Given this list of marker genes HNRNPK, CPE, AMN, EGR2, SDR9C7, IL17B, FGFR1, ALOX15B, RND2 (Rho family GTPase 2), SAPCD2, CMKLR2, SPATA17, LRSAM1, IFNA1, KCNQ4, LGI1, EDN3, ACACB, IL1RN, CBY3, SEMA4C, LYZL1, SAA2, IL1R2, PLA2G2F, ZBTB21, GALNT6, APOLD1, CD164L2, APOM, MARK1 (NCBI Gene Id 55887), HNF4A, SLC2A1, PTGS1, KDM5B, ADAMTSL2, PADI4, INSL6, CLDN7, CD33, ANKRD31, F7, HELZ2 (helicase with zinc finger 2), GNG13, SLCO2A1, LYPD8, EDARADD, MRGPRE, LOXL4, CPA1, CD70, LAMA1, AOC1, ADAMTSL1, IGSF21, MNX1, SRGN, ADRA2A, TTBK1, ADORA2B, SRXN1, CXCL1, RPH3A, HORMAD2, CKMT1B, UGT2B15, TMEM154, DMRTC2, FAM81B, PAQR5, FOSL1, PLXNB1, CASS4, FAM167B, CDKL1, GLI3, TTK, KCND2, SNAI3, PCDH11X, CALR3, MKI67, ITGB1BP2, ESRRB, TMEM174, CADM2, PABPC4L, LRRIQ3, SOCS3, TUT4, PPP1R1C, PTH, DSC3, HTR4, MGMT, DGAT2, ASPHD2, NLRP5, IL10, NID1, PCDH20, CMTM5, FST, CDKN1A, GDF15, MYOCD, ADAM19, CCDC63, CISH, FLNC, ROR1, CCDC65, CLEC4E, ALPG (NCBI Gene Id 251), PTGS2, TERB2, ARMCX4, FBLN1, NRXN1, PPP1R3B, NCAN, PPP1R1B, ITPKC, HDC, ZFP3, KATNAL2, TSPAN7, DNAJB2, MORC1 (NCBI Gene Id 27136), MXI1, PCSK6, MARCKSL1, NKAIN4, GPCPD1, ADPRHL1, SGMS1, PLEK2, STMN4, RASL10B, CCR1, SPP1, STX1B, ANKRD33, SLC2A3, PAX1, OTC, GRIK2, KCNJ12, CYB5R2, ADAMTSL3, CREB3L3, STIM2, KRT84, KLF5, GOT1L1, CFAP45, HS3ST3B1, RDH11, GRIA2, HTR1F, RILPL2, C5orf52, FHL2, FGB, ROBO3, TTN, SERPINA3, GRIN2A, HSPB8, SYTL4, SLC29A4, COX17, MMP9, MIR1915HG (NCBI Gene Id 414251), BAG2, CD40LG, CSTA, FGD4, SOCS1, CACNG3, SFTPD, PABIR1, MMD, GCGR (glucagon receptor), HS3ST1, LHX5, GNA13, MAP7, FOXM1, MAGI2, PXK, TEX38, MALL, MYOC, ETS2, DLC1 (DLC1 Rho GTPase activating protein), SYDE2, RGS7, OSBPL10, FAM217B, here is a description of the gene set: Genes up-regulated in comparison of type 2 myeloid (T2M) cells treated with IL25 versus macrophages treated with IL25. Human Gene Set: GSE36392_TYPE_2_MYELOID_VS_MAC_IL25_TREATED_LUNG_UP Many symptoms associated with allergic asthma result from the sequelae of type 2 inflammation. Interleukin (IL)-25 promotes type 2 inflammatory responses, and T2M cells represent an IL-4 and IL-13 producing granulocytic IL-25 responsive population. We used microarrays to characterize the gene expression profile of T2M cells, and compared T2M cells to other inflammatory subsets (eosinophils, neutrophils, and macrophages) in the lungs of mice with IL-25-induced pulmonary inflammation. species: Homo sapiens from publication Petersen BC, Budelsky AL, Baptist AP, Schaller MA, Lukacs NW (PMID 22543263)